Given this list of marker genes Zdhhc20, Zdhhc17, Nmt1, Zdhhc2, Scp2, Zdhhc7, Acaa1b, Zdhhc3, Acaa1a, Nmt2 (NCBI Gene Id 99235), Zdhhc15, Hadhb, here is a description of the gene set: Catalysis of the transfer of a myristoyl (CH3-12-CO-) group to an acceptor molecule. Mouse Gene Set: GOMF_MYRISTOYLTRANSFERASE_ACTIVITY studied in species Mus musculus